Given this list of marker genes RGPD5, LRRC37A2, NPIPA1, SPATA31A7, DPY19L2P2, TRIM51 (tripartite motif-containing 51), CCDC127, GUSBP14, ZNF790 (zinc finger protein 790), NBPF11, PMS2P5, GOLGA8EP, TBC1D3C, here is a description of the gene set: Human Gene Set: JIANG_CORE_DUPLICON_GENES from publication Jiang Z, Tang H, Ventura M, Cardone MF, Marques-Bonet T, She X, Pevzner PA, Eichler EE (PMID 17922013) species: Homo sapiens Genes mapped to core duplicons - elements shared by a majority of segmental duplication blocks. Human segmental duplications are hotspots for nonallelic homologous recombination leading to genomic disorders, copy-number polymorphisms and gene and transcript innovations. The complex structure and history of these regions have precluded a global evolutionary analysis. Combining a modified A-Bruijn graph algorithm with comparative genome sequence data, we identify the origin of 4,692 ancestral duplication loci and use these to cluster 437 complex duplication blocks into 24 distinct groups. The sequence-divergence data between ancestral-derivative pairs and a comparison with the chimpanzee and macaque genome support a 'punctuated' model of evolution. Our analysis reveals that human segmental duplications are frequently organized around 'core' duplicons, which are enriched for transcripts and, in some cases, encode primate-specific genes undergoing positive selection. We hypothesize that the rapid expansion and fixation of some intrachromosomal segmental duplications during great-ape evolution has been due to the selective advantage conferred by these genes and transcripts embedded within these core duplications.